The following is a description of a gene set: from publication Hedenfalk I, Ringner M, Ben-Dor A, Yakhini Z, Chen Y, Chebil G, Ach R, Loman N, Olsson H, Meltzer P, Borg A, Trent J (PMID 12610208) In the decade since their discovery, the two major breast cancer susceptibility genes BRCA1 and BRCA2, have been shown conclusively to be involved in a significant fraction of families segregating breast and ovarian cancer. However, it has become equally clear that a large proportion of families segregating breast cancer alone are not caused by mutations in BRCA1 or BRCA2. Unfortunately, despite intensive effort, the identification of additional breast cancer predisposition genes has so far been unsuccessful, presumably because of genetic heterogeneity, low penetrance, or recessive/polygenic mechanisms. These non-BRCA1/2 breast cancer families (termed BRCAx families) comprise a histopathologically heterogeneous group, further supporting their origin from multiple genetic events. Accordingly, the identification of a method to successfully subdivide BRCAx families into recognizable groups could be of considerable value to further genetic analysis. We have previously shown that global gene expression analysis can identify unique and distinct expression profiles in breast tumors from BRCA1 and BRCA2 mutation carriers. Here we show that gene expression profiling can discover novel classes among BRCAx tumors, and differentiate them from BRCA1 and BRCA2 tumors. Moreover, microarray-based comparative genomic hybridization (CGH) to cDNA arrays revealed specific somatic genetic alterations within the BRCAx subgroups. These findings illustrate that, when gene expression-based classifications are used, BRCAx families can be grouped into homogeneous subsets, thereby potentially increasing the power of conventional genetic analysis. Human Gene Set: HEDENFALK_BREAST_CANCER_BRACX_DN studied in species Homo sapiens Down-regulated genes distinguishing between two groups of non-BRCA1/BRCA2 breast tumors (BRACx): group A vs group B., and this is the list of marker genes: EHD1, FTCD, CEPT1, PRPF6, EP300, EVI5, CASD1, UBR5, AFDN, SYNCRIP, DLEU2, NAP1L1, BANP (BTG3 associated nuclear protein), FKBP8, METAP2, HPS5, SVIL (NCBI Gene Id 6840), ARHGEF7, OCIAD1, SRSF11